The following is a description of a gene set: Renal angiomyolipoma A benign renal neoplasm composed of fat, vascular, and smooth muscle elements. Human Gene Set: HP_RENAL_ANGIOMYOLIPOMA species: Homo sapiens, and this is the list of marker genes: TSC2, TSC1, MVK, IFNG, CDKN1B